The following is a description of a gene set: A type of dystonia (abnormally increased muscular tone causing fixed abnormal postures) that affects muscles of the limbs. studied in species Homo sapiens Human Gene Set: HP_LIMB_DYSTONIA Limb dystonia, and this is the list of marker genes: ANO3, IMPDH2, SLC39A14, ALS2, AFG3L2, PI4K2A, FITM2, SHH, VPS37A, GNB1, TGIF1, CDON, TAF1, VPS11, PLCH1, SYNE1, AFG2A, GLI2, WARS2, TSPOAP1, FOXH1, VPS13C, ATP1A3 (ATPase Na+/K+ transporting subunit alpha 3), STIL, GCDH, SLC6A3, SIX3, SLC35B2, CYB5R3, STAG2, MECR, ATP7B, PARK7, GNAL, GAS1, BSCL2, AARS1, GCH1, ACTB, AOPEP, FGF8, VPS16, ZIC2, NKX6-2, PNPT1, NODAL, MAPT, CHD8, GFM2, VPS13A, JAM2, COX20, SCO2, SLC18A2, DLL1, CRIPTO, DLAT, SPG11, SMC1A, THAP1, CKAP2L, DISP1, PTCH1, DDC, FTL, ARX, NUP54, TH, KMT2B, SPTLC1, COL6A3, YIF1B, UBE3C, PRKRA, SRPK3, FUS, SIGMAR1, HPCA, NR4A2, EIF2AK2, CYB5A, PANK2, TUBB4A, DTYMK, COL4A1, FGFR1